The following is a description of a gene set: species: Homo sapiens Reduced ability to flex (bend) the knee joint. Human Gene Set: HP_LIMITED_KNEE_FLEXION Limited knee flexion, and this is the list of marker genes: GPC6, VCP, FLNC, FLNA, ECEL1